Given this list of marker genes MRPS18C, KRTAP9-8, TRAF3IP3, SOCS2-AS1, SLC66A1LP, PAX5, CD276, NKX2-5, A1CF, IBSP, PRCC, DKK4, HMGB2, TIA1, ENTREP3, B3GNT9, LINC01310, AGAP3, KDM2A, SLC30A2, SCAP, ABCA17P, SLC15A4, GOLM1, FBXO3, LGALSL, PSD2, CUTALP, DHRS1, ROBO1, SMAP2, PPP2R3B, KRT38, SPOP, MOGS, CANT1, DRAIC, IFNG, WIPF2, AVP (arginine vasopressin), LYRM7, STOML3, ENSG00000290731, PIK3R1, KBTBD11, CBX1, TADA1 (transcriptional adaptor 1), IL17A, ZBTB48, ARPP19, SLC34A2, HACD2, TSPEAR-AS1, SLC16A9, LINC01128, KIRREL1, IGF2R, SCN3B, CDADC1, HLA-DRB6, STX6, MAVS, RNF34 (NCBI Gene Id 96268), KLHL12, TCP11L1, VOPP1, TENT5C, GPC1, DRC1, FKBP2, GNA12, SLC25A38, TMEM14B, CHMP4B, LDHAL6B, SPTB, DPP3, OIP5-AS1, CLASP1, MAP7D1, DCAF10, CMAS, SH3BGRL2, EVL, PPP2R2A, PELP1, SAT2, GJA4, ERCC6L2-AS1, OLIG2, NMT1, ZNF674-AS1, ISG20, DARS1, PRL, PARP3, SNHG16, KCTD20, USP22, MBNL2, BPIFA3, CTDSP1, FXR1, TMEM186, INHBB, PRMT5, ZDHHC17, GABRR2, AFG3L1P, HBD (NCBI Gene Id 3045), SCML1, CPNE6, SLF2, SNX20, RPAIN, LARP1B, CTXN1, ZCCHC17 (NCBI Gene Id 95373), LETM2, TIGD2, RNF151, KHDRBS3, PHACTR2-AS1, ARHGAP17, COX17, PILRB, TRAPPC12, FLI1 (Fli-1 proto-oncogene, ETS transcription factor), MAP2K5, ATP6AP1, WDR5B, HCG18 (NCBI Gene Id 414777), SMCHD1, S100A5, ADGRB2, CBLN4, ZNF438, BRAP, STAMBPL1, C5orf47, SLC35E2B, FMN2, TCEAL4, PHF21A, LLGL1, VKORC1, MAIP1, PLEKHA8, TBC1D24, PPIH, CSRNP2, KCNA1, ZC3H7A, CLCN1, TPD52, PBDC1, MEF2D, ZNF830, POLR3A, PALB2, TP53BP2, NME1, EXOC1, SEL1L3, ZC3HC1, SLC7A6OS, MT1X, EMC4, CHRNB1, PAQR8, RNF187, PWAR5, ZNF182, PRIMPOL, CAPN7, HPSE, MLH1, CDCA4, ARID3B, HSD17B7, NTSR1, IKBKB, LINC00347, TOMM20, SCOC-AS1 (NCBI Gene Id 124900785), KCND2, LRP1, SMIM17, SNCA, ARHGEF11, B3GNT6, LRRN2, ARHGDIA, EML3, UTP25, here is a description of the gene set: from publication Doering TA, Crawford A, Angelosanto JM, Paley MA, Ziegler CG, Wherry EJ (PMID 23159438) species: Homo sapiens Human Gene Set: GSE41867_NAIVE_VS_DAY8_LCMV_CLONE13_EFFECTOR_CD8_TCELL_DN During acute viral infections, naïve CD8+ T cells differentiate into effector CD8+ T cells and, after viral control, into memory CD8+ T cells. Memory CD8+ T cells are highly functional, proliferate rapidly upon reinfection and persist long-term without antigen. In contrast, during chronic infections, CD8+ T cells become “exhausted” and have poor effector function, express multiple inhibitory receptors, possess low proliferative capacity, and cannot persist without antigen. To compare the development of functional memory T cells with poorly functional exhausted T cells, we generated longitudinal transcriptional profiles for each. Genes down-regulated in CD8 T cells: naïve versus effectors at day 8 chronic infection with LCMV-clone 13.